Given this list of marker genes MIB2, NEURL1, JAG1, MIB1, NEURL1B, DLL1, JAG2, DLL3, DLL4, here is a description of the gene set: Notch ligand ubiquitylation. Pathway ID: N01479. Pathway type: Reference. Pathway class: nt06511 NOTCH signaling. species: Homo sapiens Human Gene Set: KEGG_MEDICUS_REFERENCE_NOTCH_LIGAND_UBIQUITYLATION Pathway Definition from KEGG: (MIB,NEUR) -> (DLL,JAG)